The following is a description of a gene set: 2-methoxyestradiol (2ME2), an estradiol metabolite with antiproliferative and antiangiogenic activities, is in phase I/II clinical trials for breast cancer. 2ME2 inhibits microtubule polymerization and causes cells to arrest in G2-M. The purpose of this study was to further elucidate the molecular mechanism of 2ME2. MDA-MB-435 breast cancer cells were treated with 2ME2 (2 micromol/L) or vehicle alone. RNA was extracted and genomic profiling was done using 22k Agilent microarrays. Expression Analysis Systematic Explorer was used to determine enrichment of Gene Ontology categories. Protein isolates were subjected to Western blot analysis. Protein synthesis was measured with amethionine pulse assay. An MDA-MB-435 cell line with two beta-tubulin mutations (2ME2R) was used to determine whether novel mechanisms were tubulin-dependent. Gene Ontology categories enriched include genes that regulate the mitotic spindle assembly checkpoint, apoptosis, and the cytosolic ribosome. The target of the mitotic spindle assembly checkpoint is the anaphase-promoting complex (APC). APC inhibition was confirmed by measuring protein levels of its targets securin and cyclin B1, which were increased in 2ME2-treated cells. Because gene expression in the cytosolic ribosome category was decreased, we evaluated whether 2ME2 decreases protein translation. This was confirmed with a pulse assay, which showed decreased isotope incorporation in 2ME2-treated cells, which was maintained in the tubulin-resistant 2ME2R cells. APC inhibition was not maintained in 2ME2R cells. 2ME2 induces tubulin-dependent cell cycle arrest through regulation of genes involved in the mitotic spindle assembly checkpoint, which results in inhibition of the APC and tubulin-independent inhibition of protein translation. from publication Bhati R, Gökmen-Polar Y, Sledge GW Jr, Fan C, Nakshatri H, Ketelsen D, Borchers CH, Dial MJ, Patterson C, Klauber-DeMore N (PMID 17234781) Human Gene Set: BHATI_G2M_ARREST_BY_2METHOXYESTRADIOL_DN species: Homo sapiens Down-regulated genes in MDA-MB-435 cells (breast cancer) undergoing G2/M arrest after treatment with 2-methoxyestradiol (2ME2)., and this is the list of marker genes: ABHD14B, GPT2, TMEM79, SNAPC5, MT1F, AIG1, THRA, ARHGAP24, MLANA, DNASE2, RBM3, NUPR1, PYCR1, CLIC6, SCRG1, B3GALT6, KRCC1 (NCBI Gene Id 51315), IGDCC3, NOP53, TCF7L1, PRTFDC1, ZNF658, MACROD1, DENND2D, SIX6 (SIX homeobox 6), CSNK2A2, RPS2, NOA1, PRKCZ, RPL26, SARS1, PRKAG1, AARS1, MID1IP1, IGBP1, NLGN1, CCNB1IP1, PGLS, ZNF581, MTHFD2, FANCF, BOLA1, HELQ, CEBPG, CRTAP, RPL36A, VMO1, ELAC1, RCSD1, RHAG, AMPD3 (NCBI Gene Id 272), NEURL2, CCL20, EIF2S3, PVALB, JRKL, CBS, EEF2, CIRBP, GCHFR, DCN (decorin), GARS1, CEP104, TMPRSS4, MRNIP, RPL34, SPSB2, FGB, HERPUD1, C1orf54, BFSP1, EEF2KMT, CAST, OGDHL, CD3G, ZNF490, SIRPA, NIPAL3, PDE8B, EPRS1, RPL10A, ZNF277, CTH, METTL9, PSAT1 (NCBI Gene Id 29968), GDF3, IFRD1, RPS17, ZNF613, SLCO2B1, NOSTRIN, ZFAND1, ATF4, SMOC2, PER2, SESN2, SGSH, RPS2P32, RPL31, DET1, TYRP1, AK7, IL1A, LENG1, RPL3, SCUBE2, TPCN2, RPL12, TRIB3, MYL5, LCK, STAR, BAG1, HCAR1, C5, HLA-E, XK (NCBI Gene Id 7504), GFI1, LAPTM5, ZFP62, LARP6, P2RY2, ARHGAP9, MPND, TIMP4, ZBED3